The following is a description of a gene set: Genes down-regulated in comparison of B cells versus basophils. In the present study we used Affymetrix oligonucleotide microarrays to produce gene transcription profiles for the major leukocyte types in humans. This comprehensive dataset enabled us to not only establish which genes were expressed in each leukocyte type, but also which genes were expressed in each subset after activation. The used of a comprehensive dataset of gene profiles from all the major human leukocyte subsets enabled a novel and powerful means for identification of genes associated with single leukocyte subsets, or different immune paradigms. Human Gene Set: GSE3982_BCELL_VS_BASOPHIL_DN studied in species Homo sapiens from publication Jeffrey KL, Brummer T, Rolph MS, Liu SM, Callejas NA, Grumont RJ, Gillieron C, Mackay F, Grey S, Camps M, Rommel C, Gerondakis SD, Mackay CR (PMID 16474395), and this is the list of marker genes: PTGES, ELF1, NLGN1, SEMA3C, CREG1, TBX10, PIAS3, VEGFA, OSBPL3, S100P, FOXJ2, WDR1, FRMPD1, ATP2B4, CHPT1, LPAR6, CD3G, BST1, TALDO1, CD3D, INTS12, HMGA2, CST3, SMAD7, DBI, SGPP1, PDE6G, CST7, B2M, NRDC, GRB10, RIMS3, CX3CR1, PCTP, MEOX2 (NCBI Gene Id 4223), CYP1A1, CDHR1, ABHD5, DYNLT1 (dynein light chain Tctex-type 1), EMX2, CFAP45, NECAP1, CXCL8, GDNF, MYB, TLR8, REPS2, BABAM2, CCR5, CHST11, TACR3, SELPLG, KDM5A, GZMA, LRP12, FAM186A, DAZAP2, PDGFC, HP, TLX2 (T cell leukemia homeobox 2), ZDHHC7, ACTR2, FUCA1, ZNF674, PBX3, TUBB2B, ADGRE5, JARID2, UBAP2L, LAPTM4A (lysosomal protein transmembrane 4 alpha), COX6C, SERINC3, SLC25A44, SCGB1D2, BMP3, CRIM1, CDH2, SEMA4C, LYPD1, MPP1, SLC12A6, EFNA1, NME8, NFE2, CDA, MBP, RRAGD, ABCC5, KLF3, ADCY10, HRH3, OSGIN2, SIRPA, DPEP2, HOXA4 (NCBI Gene Id 3201), FAM66D, IL32, PARP4, SORL1, SLC4A1AP (NCBI Gene Id 55189), PAX3, GRIA2, GSTO1, PSTPIP2, H3C10, TREM2, ZRSR2P1, NECTIN3, ARPC5, RASSF2, FAR2, UBB, FOXO3, PPP2R5A, PDCD4-AS1, RFX4, ITK, UBE2D3, PYY2, PRSS2, S100A8, PSMD1, FRY, SDC3, ATP1B2, C1RL, ITPRID2, SLC2A10, MS4A5, KANSL1L, ZNF148, SERINC1, RNF10 (NCBI Gene Id 9921), MRC2, OPRM1, SEC23B, FBXL5, PALLD, VCL, RAB31, DDO, DRAM1, ACVR1, PLGRKT, TLR4, ATP2C2, H1-0, GLUL, ELOVL4, PTP4A1, FNBP1L, POGZ, MYRIP, MAP1LC3B, SH2D1A, MAPKAPK5-AS1 (MAPKAPK5 antisense RNA 1), DBH, CEBPB, DENND3, ADH1C, BIN2, ITGA9, SNCAIP, TPT1, FCGR3B, ADIPOR2, DUSP1, SEMA4D (semaphorin 4D), CA8, PILRA, CKLF, PRR5L, RTN3, SERPIND1, VIP, MNX1, TNFSF11, CTNNBL1, RNFT1, SPINK1, FLT3, MTRF1L, TPST2, SYCP2, NLK (nemo like kinase), TMEM59, SFXN1, C21orf91, ETS2, WIF1, FAM124B, ADGRE1, SOX13, NDUFS1, GNAS, TOB1, CD9 (NCBI Gene Id 928), BHLHE40, PAK5, GLRA3